Given this list of marker genes GYS2, GBE1, GYG2 (glycogenin 2), here is a description of the gene set: Reactome Pathway: Glycogen storage disease type IV (GBE1) species: Homo sapiens Normally, cytosolic glycogen branching enzyme (GBE1) associated with glycogen granules transfers terminal alpha(1,4) glucose blocks to form alpha(1,6) branches on growing glycogen molecules of both liver and muscle types. In the absence of GBE1 activity, abnormal amylopectin-like glycogen with longer alpha(1,4) chains and fewer branch points forms in all tissues where glycogen is normally found. Presentation of the disease is clinically heterogeneous: missense and nonsense mutations associated with little or no enzyme activity can lead to progressive liver disease or neuromuscuolar disease. part of: Glycogen storage diseases